The following is a description of a gene set: Reactome Pathway: Ubiquitin-dependent degradation of Cyclin D electronically inferred by orthology from the curated human pathway part of: S Phase This event has been computationally inferred from an event that has been demonstrated in another species.<p>The inference is based on the homology mapping from PANTHER. Briefly, reactions for which all involved PhysicalEntities (in input, output and catalyst) have a mapped orthologue/paralogue (for complexes at least 75% of components must have a mapping) are inferred to the other species. species: Mus musculus, and this is the list of marker genes: Psmd13, Psmc3, Psmc4, Psmd1, Psma6, Psmd6, Psmc2, Psma7, Cdk4, Psmc5, Ubb, Psma2 (proteasome subunit alpha 2), Psma5, Psmb4, Psmc6, Psmb5, Psmd7, Psma3, Psmd12, Psmc1, Psmb7, Ccnd1, Psma1, Psmb6, Rps27a, Psma4